The following is a description of a gene set: Genes down-regulated in cells from Flt3L Melanom injected mice: 33D1+ versus CD4 T cells. from publication Dudziak D, Kamphorst AO, Heidkamp GF, Buchholz VR, Trumpfheller C, Yamazaki S, Cheong C, Liu K, Lee HW, Park CG, Steinman RM, Nussenzweig MC (PMID 17204652) Human Gene Set: GSE6259_FLT3L_INDUCED_33D1_POS_DC_VS_CD8_TCELL_DN species: Homo sapiens Dendritic cells (DCs) process and present self and foreign antigens to induce tolerance or immunity. In vitro models suggest that induction of immunity is controlled by regulating the presentation of antigen, but little is known about how DCs control antigen presentation in vivo. To examine antigen processing and presentation in vivo we specifically targeted antigens to the two major subsets of DCs using chimeric monoclonal antibodies. Unlike CD8+ DCs that express the cell surface protein CD205, CD8- DCs, which are positive for the 33D1 antigen, are specialized for presentation on MHC class II. This difference in antigen processing is intrinsic to the DC subsets and associated with increased expression of proteins associated with MHC processing., and this is the list of marker genes: CCL22, MICAL1, IQCF3, CSTA, DNA2, NCLN, VASP, USP12 (NCBI Gene Id 219333), FDPS, CFHR1, ALDOC, TSPAN33, MMP2, ADGRL3, CCL17, LTA4H, TCTN3, SLC44A2, CFAP263, TGFBI, NOP16, ITM2C, MDH2, GTF2H2, RGS1, C1orf54, ALDOA, TOMM70, YJU2, PIP5K1C, NONO (NCBI Gene Id 8253), SORL1, TSPAN13, GRAP2, ZMAT4, TNNI2, PLPP5, CD74, CTSZ (NCBI Gene Id 1522), PILRA, CEP43, RPL14, AFG2B, DOCK5, HIC1, MMP12 (matrix metallopeptidase 12), CD72, SLC35G3, ACP5, CST7, DUS4L, THAP12, SLC35C2, NAPSA, ITGAX, PRSS45P, CARD11 (NCBI Gene Id 84433), TKT, AP1S1, TBC1D8, SEC14L3, ATOX1, GZF1, GM2A, PYGL, GYG1, AMPH, LYPLA2, LAG3, MIR216B, TALDO1, LSM5, PDCD1LG2, BTBD16, CRIPTO, IFI30, DMXL2, HCLS1, CATSPER4, JAML, RUNX2, CADM1, DNASE1L3, PDCL3, CD22, ABR, ITGA8, DPP4, KLHL1, NR2F6, DTX4, ANPEP, FANCB, RPA1, MANSC1, OSBPL3, CSF2RA, CD9, SLC22A9, SLC25A38, ITGA9, SSR1, AXL, TGFBR1 (transforming growth factor beta receptor 1), DPPA3, PRMT6, PMEPA1, ALCAM, OLFML3, MORC1, GDE1, SYNE1, GPM6B, ADGRG5, FUCA2, MAB21L3, GTF2F2, ADAMDEC1, NFKBIE, PFKP, ODAD4, HEBP1, IHO1, BHLHE40 (basic helix-loop-helix family member e40), GAB2, NMT1, ART3, APOC2 (apolipoprotein C2), RAB27A, MTERF2, CCDC134, H1-6, EIF2AK1, HTATIP2, CIDEB, TSSK2, PLA2G7, CTPS1, PEX10, IL12B, AKNA, ACVRL1 (NCBI Gene Id 94), HAUS8, MBD2, GAMT, FBXO42 (F-box protein 42), KYNU, CS, TMEM154 (transmembrane protein 154), PSMC3